The following is a description of a gene set: studied in species Homo sapiens Genes up-regulated in plasmacytoid dendritic cells: wildtype versus TCF4 heterozygous knockout. from publication Cisse B, Caton ML, Lehner M, Maeda T, Scheu S, Locksley R, Holmberg D, Zweier C, den Hollander NS, Kant SG, Holter W, Rauch A, Zhuang Y, Reizis B (PMID 18854153) Analysis of expression profiles of pDCs from wild type and heterozygous E2-2 mice. Results show the control by E2-2 of the expression of pDC-enriched genes. Human Gene Set: GSE12505_WT_VS_E2_2_HET_PDC_UP, and this is the list of marker genes: UNC80, SACS, RHOG, ZFP3, RAB20, TAT, IGFBPL1, MIR328, MIR181D, FGF23, ZBTB43, RNF123, VPS11, ZBTB4, MINPP1, ZIC3, ITGB7, TIFAB, CACNA1F (calcium voltage-gated channel subunit alpha1 F), SPHK1, AMPD1, LCN9, DYNLT5, BTBD6, TMCO2, TAFA4, PCNX1, BAZ2A, PNMT, COL12A1, IRF7, ACKR3, FAM180A, ASIC4, KCNAB1, DCST2, IGDCC4, IL17B, FCGR3A, STX3, UBALD1, ARHGAP45, AXIN2, COMP, PRSS42P, FMNL2, ADAMTS4, FAHD1, SMAD3, TMED8 (transmembrane p24 trafficking protein family member 8), FMO3, CDC42EP2, RPS6KA2, F10, TRMT10B, MDGA1, KL, C16orf54, GRB7, GNS, NOTCH4, VRK3, POLR1D, MRPL9, PKLR, USP18, FEM1A, PTK7, C1QC, CLEC7A, CABP5, ALKAL1, FFAR4, TRIM66, WDR45B, DLL1, GSDMA, SIKE1, PANX1, PAX3, EBF2, PTPRU, ARHGDIB, CHRNG, KRT23, CD27, PAF1, TFIP11, SLC16A5, SAP30BP, RPS9, GRIPAP1, PLEKHM1, TSPAN18, FOXI2, CYP17A1, CDH8, B4GALNT3, ABHD1, PRELP, UNC79, ANKRD60 (ankyrin repeat domain 60), TGFBR3, ARFGEF2, ATG2A, ADRB1, CASP6, DNAAF11, NECAB2, RTN4RL2, HDGFL1, ABLIM3, ITPKB, WDR12, CLEC1B, RIC3, HHIPL1, DYRK2, RHBDL1, ZSCAN10, DUSP28, GGT1, SLC23A2, EMX2, H6PD, KLRG2, CLTA, SLC11A1, OTOP2, COL6A1, CDH17